The following is a description of a gene set: Sensorineural hearing impairment with childhood onset. Human Gene Set: HP_CHILDHOOD_ONSET_SENSORINEURAL_HEARING_IMPAIRMENT studied in species Homo sapiens Childhood onset sensorineural hearing impairment, and this is the list of marker genes: MARVELD2, ATP2B2, GIPC3, GJB2 (NCBI Gene Id 2706), ADCY1, TK2, NDE1, RIPOR2, IGF1, IARS2, GJB6, PRG4, FOXP2, SARDH, CDH23, ESPN, SETBP1, COCH, HGF, TIMM8A